The following is a description of a gene set: Mouse Gene Set: REACTOME_FATTY_ACIDS_BOUND_TO_GPR40_FFAR1_REGULATE_INSULIN_SECRETION Fatty Acids bound to GPR40 (FFAR1) regulate insulin secretion species: Mus musculus, and this is the list of marker genes: Gna14, Ffar1, Gnaq, Plcb3, Gna11, Gna15, Plcb2, Plcb1